The following is a description of a gene set: species: Homo sapiens Binding to a component of the extracellular matrix. Human Gene Set: GOMF_EXTRACELLULAR_MATRIX_BINDING, and this is the list of marker genes: VTN, SHH, VEGFA, LRRC15, SMOC2, CCN1, VWA1, ADAMTS5, ITGA3, NTN4, SSC5D, BCAM, TGFBI, ITGB1, LGALS1, SPOCK1 (NCBI Gene Id 6695), DCN, ITGB3, PLEKHA2, ITGAV, CHADL, CLEC14A, DMP1, ITGA2B, PXDN, POLR2A, OLFML2B, RPSA, NID1, BGN, SLIT2, CTSS, TNXB, SPARC, LTBP2, DAG1, LACRT, SPARCL1, CD248, THBS1 (thrombospondin 1), ACHE, ADGRG1, AGRN, ADAMTSL2, FBLN2, SMOC1, ITGA2, SPOCK3 (NCBI Gene Id 50859), RPSA2, SPP1, TINAGL1, ADAMTS15, COL11A1, THSD1, LTBP1, ADGRG6, FKRP, ADAMTSL5, AMBP, ADAM9, LYPD3, OLFML2A, LGALS3, GPC1, SPOCK2, ELN